Given this list of marker genes CCL20, BHLHE40, NEAT1, ST3GAL1, GPRC5A (NCBI Gene Id 9052), IRF1, DDIT3, DDIT4, HERPUD1, ATF3, PTGS2, SELE, NRIP1, BMP2, SLC7A5, DEPP1, CXCL3, SEMA3C, TRIM33, CXCL2, KLF7, DHRS3, here is a description of the gene set: from publication Ferrari N, Pfeffer U, Dell'Eva R, Ambrosini C, Noonan DM, Albini A (PMID 15958647) PURPOSE: Tumor growth appears to be an angiogenesis-dependent process. N-(4-hydroxyphenyl)retinamide (fenretinide; 4HPR) has been found to inhibit and/or prevent tumor growth under diverse conditions. Although 4HPR is antiangiogenic, the molecular mechanisms of this effect remain largely unknown. EXPERIMENTAL DESIGN: Endothelial cells were treated with 4HPR in vitro to study the effects on migration, invasion, and organization, as well as gene expression by microarray and quantitative PCR studies. In vivo angiogenesis was evaluated in the Matrigel model. RESULTS: 4HPR treatment substantially modified the biological activities of endothelial cells, repressing their capacity to migrate, invade, and organize into capillary-like structures. The inhibition of invasion induced by 4HPR was also associated with decreased activities of the metalloproteases matrix metalloproteinase-2 and CD13/APN. Using oligonucleotide microarrays, we observed that bone morphogenetic protein-2 and macrophage inhibitory cytokine-1, two multifunctional cytokines of the transforming growth factor-beta family that regulate the growth, differentiation, apoptosis, and matrix accumulation of a variety of cells, are up-regulated in vitro by 4HPR. Both these molecules specifically inhibited endothelial cell growth, migration, and invasion in vitro and suppressed angiogenesis in the Matrigel plug assay in vivo. Blocking antibodies to bone morphogenetic protein-2 were able to reverse the suppressive effects of 4HPR in vitro and in vivo. CONCLUSIONS: These data support the conclusion that 4HPR inhibits tumor growth by repression of new vessel growth and identify novel points of regulation of angiogenesis in transforming growth factor-beta family proteins. Human Gene Set: FERRARI_RESPONSE_TO_FENRETINIDE_UP studied in species Homo sapiens Genes up-regulated in HUVEC cells (umbilical vein endothelium) by fenretinide.